Given this list of marker genes Enpp2, Gna11, Gnb1, Gnaq, Gnas, here is a description of the gene set: Mouse Gene Set: GOMF_ALKYLGLYCEROPHOSPHOETHANOLAMINE_PHOSPHODIESTERASE_ACTIVITY studied in species Mus musculus Catalysis of the reaction: H2O + 1-alkyl-sn-glycero-3-phosphoethanolamine = ethanolamine + 1-alkyl-sn-glycerol 3-phosphate.